The following is a description of a gene set: The condensin I complex is evolutionarily conserved and consists of five subunits: two SMC (structural maintenance of chromosomes) family subunits, SMC2 and SMC4, and three non-SMC subunits, NCAPD2, NCAPH and NCAPG. The stoichiometry of the complex is 1:1:1:1:1. SMC2 and SMC4 subunits, shared between condensin I and condensin II, are DNA-dependent ATPases, and condensins are able to introduce positive supercoils into DNA in an ATP-dependent manner. <br><br>Protein levels of condensin subunits are constant during the cell cycle, however condensins are enriched on mitotic chromosomes. Four of the five subunits, SMC4, NCAPD2, NCAPG and NCAPH, are phosphorylated in both mitotic and interphase HeLa cells, but on different sites. CDK1 (CDC2) in complex with CCNB (cyclin B) phosphorylates NCAPD2, NCAPG and NCAPH in mitosis, but other mitotic kinases, such as PLK1, and other post-translational modifications, such as acetylation, may also be involved. Global proteomic analysis of human cell lines has identified N6-acetylation of lysine residues in condensin subunits SMC2, SMC4 and NCAPH. Another high throughput proteomic study showed that condensin I subunits NCAPD2 and NCAPH are phosphorylated upon DNA damage, probably by ATM or ATR kinase.<br><br> As condensin I is cytosolic, it gains access to chromosomes only after the nuclear envelope breakdown at the start of prometaphase. Condensin I, activated by CDK1-mediated phosphorylation, promotes hypercondensation of chromosomes that were condensed in prophase through the action of condensin II. AURKB may also regulate association of condensin I complex with chromatin. Protein phosphatase PP2A acts independently of its catalytic activity to target condensin II complex to chromatin, but does not interact with condensin I. Full activation of condensin I requires dephosphorylation of sites modified by CK2 during interphase. Besides being essential for chromosome condensation in mitosis, condensin I may also contribute to cohesin removal from chromosome arms in prometaphase, but the exact mechanism is not known. studied in species Homo sapiens part of: Mitotic Prometaphase Reactome Pathway: Condensation of Prometaphase Chromosomes, and this is the list of marker genes: CCNB2, NCAPH, CSNK2A1, CDK1, NCAPG, SMC4, SMC2, NCAPD2, CSNK2A2, CCNB1, CSNK2B